The following is a description of a gene set: Human Gene Set: GSE10325_CD4_TCELL_VS_MYELOID_UP studied in species Homo sapiens Gene expression profile studies have identified an interferon signature in whole blood or mononuclear cell samples from patients with systemic lupus erythematosus. This study was designed to determine whether specific lymphocyte and myeloid subsets freshly isolated from the blood of systemic lupus erythematosus patients demonstrated unique gene expression profiles compared to subsets isolated from healthy controls. Genes up-regulated in comparison of healthy CD4 T cells versus healthy myeloid cells. from publication Hutcheson J, Scatizzi JC, Siddiqui AM, Haines GK 3rd, Wu T, Li QZ, Davis LS, Mohan C, Perlman H (PMID 18275831), and this is the list of marker genes: GPA33, SYNE1, S1PR1, ICOS, SYNE2, DHRS3, PRKCQ, SOCS2, RGCC, LRRN3 (leucine rich repeat neuronal 3), MGAT4A, APBA2, ST13, CD226, DNAJB1, LEPROTL1 (leptin receptor overlapping transcript like 1), PIK3IP1, SFI1, UBASH3A, RLIG1, INPP4B, TNIK, MAF, GPR171, LEF1, CD96, NCAPD3, FAM162A, POLR1E, DNMT1 (DNA methyltransferase 1), ZAP70, MRFAP1L1, FAM171A1 (NCBI Gene Id 90061), NCK2 (NCBI Gene Id 8440), CFAP298, POLR3E, ITPKB, TRAF1, TRBV10-2, LPIN2, KLHDC2, RAB33A, SIRPG, CEP68, LDLRAP1, PBXIP1, CYLD, IL11RA, ALDOC, ITK, TRAT1, SRSF8, ANKRD55, CLUAP1, ZBTB25, PIM1, RUVBL1, TNFRSF25, BAG3, ITGA6, CD2, BCL2, BCL11B, BDH1, AKTIP, KAT6B, WDR82, BCR, SAE1, LDHB, CDR2, DOCK9, CD247, RNF144A, PRKCH, ASF1A, TMEM204, PNMA1, TRAC, TRADD, SMYD2, IL32, ITM2A, CCT4 (NCBI Gene Id 10575), TPR, TRAV8-3 (T cell receptor alpha variable 8-3), RORA, BUB3, ENO2, IL2RB, NAE1, NOSIP, PIK3R1, STAT4, PTPN4, DPP4, CLEC2D, MYC, CD6, REXO2, EVL, GZMK (granzyme K), GVINP1, TGFBR3, PLEKHB1, LANCL1 (NCBI Gene Id 10314), ZNF32, PLXDC1, FLT3LG, MRPS30 (NCBI Gene Id 51331), MAN1C1, TXK, DGKA, ZEB1, RALGDS, RPA2, SOD1, UFSP2, PCID2, PLAAT4, DEXI, SLC2A4RG, PEX3, UXS1, EFCAB14, LCK, SKAP1, NELL2, SH2D1A (NCBI Gene Id 4068), CCSER2, CISH, HIVEP2, ANK3, AP3M2, PIGC, ATP6V0E2, KLRB1, SLC39A8, PRKCA, BLMH, TCF7, HSPA8, DENND2D, PLPP1, FBLN5, CCNG1, GPX7, AKT3, BEX4, AQP3, MSH2, NGRN, ARHGAP15, LINC00623, HMOX2, SFXN1, LRIG1, FHIT, FAM50B, SPOCK2, TRDV2, OPTN, EEIG1, ZMYND11, MAL, DYRK2, CD28, KLHL3, LPXN, GATA3, SATB1, MYBL1, LTBP3, CD3D, PTPN7, AMZ2, CD3G, ESYT1, NUCB2, ARL4C, KIF2A, PLCG1, MAST4, MLLT3, GIMAP5, ZNF512B, TBC1D4, TMEM63A, RSL1D1, ADPRM, SUPT3H (NCBI Gene Id 8464), ASTE1, NCALD, USP20, CCND2, RAN (RAN, member RAS oncogene family), TKTL1, SNRPF (small nuclear ribonucleoprotein polypeptide F), TESPA1